Given this list of marker genes UCP3, LIPA, ABCB4, ZNF683, GOLPH3, ZC3H12A, PLCB1, CFL1, ITGAM, AKT1, FOXP3, CRH (NCBI Gene Id 1392), CAV3, CYP1A1, PRKN, CDK4, HNRNPD, LARP1 (La ribonucleoprotein 1, translational regulator), OXT, MDM2, CD4, IFITM5, here is a description of the gene set: species: Homo sapiens Human Gene Set: GOBP_RESPONSE_TO_ETHER Any process that results in a change in state or activity of a cell or an organism (in terms of movement, secretion, enzyme production, gene expression, etc.) as a result of a ether stimulus.